The following is a description of a gene set: Steroid hormone precursor biosynthesis studied in species Homo sapiens Human Gene Set: WP_STEROID_HORMONE_PRECURSOR_BIOSYNTHESIS, and this is the list of marker genes: AKR1D1, CYP21A2, AKR1C1, CYP11A1, CYP17A1, SRD5A1, SRD5A2, HSD3B1, HSD3B2